Given this list of marker genes Cad, Dtymk, Cmpk1, Umps, Ak9, Cmpk2, Dhodh, here is a description of the gene set: Mouse Gene Set: GOBP_PYRIMIDINE_NUCLEOSIDE_DIPHOSPHATE_BIOSYNTHETIC_PROCESS studied in species Mus musculus The chemical reactions and pathways resulting in the formation of pyrimidine nucleoside diphosphate, a compound consisting of a pyrimidine base linked to a ribose or deoxyribose sugar esterified with diphosphate on the sugar.